Given this list of marker genes CMA1, FZD2, AK8, PCDH7 (NCBI Gene Id 90855), CENATAC, WDR86, SGCG, TK2, PDHX, SH3BP5, DUS4L, C1QC, KCTD13, ZCWPW2, DOCK1, SELENOO, RHOBTB3, DCAKD, NOL4, CILP, MOCS3, KLC1, TFAP2D, PLA2G1B, PTK6, XKRX, MFHAS1, SLC6A12, TUBB4B, RCN3, NKX6-1, BORCS8, ZC3H8, RBAK, GEMIN5, RUFY2, SELENON, DMBX1, FXYD2, GARNL3, SLC66A2, TIMM9, TSPAN4, EMILIN1 (NCBI Gene Id 25883), CDX4, ZFYVE1, ATF6B, GSDME, RBMX, DRC3, CRABP2, MIA2, SYCE3 (NCBI Gene Id 649274), AEN, CCL7, KRT72, PGC, CFAP52, CAPN12, CYP26A1, LGI3, EXOC8, FOSL1, UBAC1, TMEM25, RAI2, SNCG, SPO11, RPGRIP1, SATB1, GPR180, DLX6, ASIC3, CABP2, YAE1, FAM3B, SLC22A4, CCL13, TNFRSF11B, STUB1, DRAM1, SEMA7A, ZFAND3 (NCBI Gene Id 60685), MYDGF, MLKL, PMP22, ZPBP, FOXK2, CSPG5, HES3, GPR6, TRMT13, SLC25A44, AZGP1, ALDOAP2, KRTAP19-1, C8orf34, SLC6A1, RTF1, CD200, KRTAP19-5, INIP, KLK7, GAD2, BEX4, TPD52L1, CTH, ELMO2, CMAS, GLIPR1L1, ZDHHC18, MRPL19, MTNAP1, ZHX1, ZBTB7C (NCBI Gene Id 649379), PNLIPRP1, BBS12, CCND1, ANGEL1, SP5, FAM163B, DPH6, FLG, CLTRN, AAR2, COMMD3 (COMM domain containing 3), IGSF23, PROK2, MPPED2, ONECUT3, CDHR2, RAD23A, DPPA5, YIPF2, STOML1, KRT2, PWWP2A, WRAP73, PCP4, TRIM68, SHF, MGAM, MYRFL, MDGA2, ABI3, EVA1C, FOXE3, TMEM72, SH3D21, HOXA10, AADAT, SLC25A32, LRRC8E, PRPH2, MYO10, GJA1, NDUFB10, RCVRN, LHFPL4, PPFIA2, BRF2, GJC3, ARPP21, DNAJC5G (NCBI Gene Id 285126), KEAP1 (kelch like ECH associated protein 1), GSDMD, UVSSA, CFAP410, PSMD7, CCDC141, ZBTB40, HACD1, GPX3, CAPN13, ZNF324B, SPATA19, MYOM1, CRYGS, SEMA3F, RNASEL, PMP2, TTLL6, THEM5, GARIN2, METTL14, HORMAD1, NXF2, ACSS2, CTBP2, ILRUN, DGKI, DUSP28, TSEN15, OR52N4, NEUROD6, WFDC2, FGF20, MACROH2A2, PATJ, GTSF1L, here is a description of the gene set: Genes up-regualted in comparison of regulatory T cell (Treg) from CBFB deficient mice versus those from wild type animals. Human Gene Set: GSE18148_CBFB_KO_VS_WT_TREG_UP from publication Kitoh A, Ono M, Naoe Y, Ohkura N, Yamaguchi T, Yaguchi H, Kitabayashi I, Tsukada T, Nomura T, Miyachi Y, Taniuchi I, Sakaguchi S (PMID 19800266) species: Homo sapiens Gene expression profiles of Cbfb-deficient and control Treg cells were compared. Naturally arising regulatory T (Treg) cells express the transcription factor FoxP3, which critically controls the development and function of Treg cells. FoxP3 interacts with another transcription factor Runx1 (also known as AML1). Here we showed that Treg cell-specific deficiency of Cbfβ, a cofactor for all Runx proteins, or that of Runx1, but not Runx3, induced lymphoproliferation, autoimmune disease, and hyper-production of IgE. Cbfb-deleted Treg cells exhibited impaired suppressive function in vitro and in vivo, with altered gene expression profiles including attenuated expression of FoxP3 and high expression of interleukin-4. The Runx complex bound to more than 3000 gene loci in Treg cells, including the Foxp3 regulatory regions and the Il4 silencer. In addition, knockdown of RUNX1 showed that RUNX1 is required for the optimal regulation of FoxP3 expression in human T cells. Taken together, our results indicate that the Runx1-Cbfβ heterodimer is indispensable for in vivo Treg cell function, in particular, suppressive activity and optimal expression of FoxP3.